The following is a description of a gene set: species: Mus musculus Mouse Gene Set: GOBP_POSITIVE_REGULATION_OF_PROTEIN_UBIQUITINATION Any process that activates or increases the frequency, rate or extent of the addition of ubiquitin groups to a protein., and this is the list of marker genes: Peli1, Arrdc4, Ube3a, Dnajb2, Rassf5, Ndfip2, Bcl10, Derl1, Fam107a, Hamp, Plk1, Ube2l3 (NCBI Gene Id 98018), Mycbp2, Spsb4 (splA/ryanodine receptor domain and SOCS box containing 4), Kdm1a, Cul3, Aimp2, Fbxo4, Skp2, Nmi, Mapk15, Fanci, D1Pas1, Paxip1, Pttg1ip, Fancm, Stub1, Btrc, Nsmce3, Amer1, Nod2, Axin1, Fbxw7, Marchf7, Rnf180, Cdk5rap3, Bmi1, Phf23, Mastl, Ube2v2, Ngf, Ptpn22 (protein tyrosine phosphatase, non-receptor type 22 (lymphoid)), Xiap, Rnf40, Prkn, Rbx1, Trib2, Angpt1, Fzr1, Birc3, Ube2n (NCBI Gene Id 93765), Arrb1, Ubqln1, Tm9sf5, Tspyl5, Laptm5, Rnf111, Mapk8 (NCBI Gene Id 26419), Sphk1 (sphingosine kinase 1), Mapk9, Klhl40, Dnaja3, Birc2, Cdc20, Birc5, Ripk2, Tbc1d7 (NCBI Gene Id 67046), Skp1, Arrdc3, Senp2, Rps2, Huwe1, Ndfip1, Cblb, Ube2srt, Septin4, Wbp1l (WW domain binding protein 1 like), Ube2d1, Fgfr3, Cd300ld3, Nhlrc1, Pef1, Gsk3a (glycogen synthase kinase 3 alpha), Wfs1, Pdcd6, Hspa5, Rbx1-ps, Pten, Psmd10, Rassf1, Ube2v1, Cav1, Npm1, Ube2s, Gabarap, Cdc14b, Trib3 (tribbles pseudokinase 3), Hamp2, Ubb, Rchy1, Birc7, Trib1, Cry1, Hspbp1, Ticam1, Hdac3, Inava, Chfr, Commd1, Mta1, Sprtn, Nscme3l, Prickle1, Lrrk2, Gsk3b, Topors (topoisomerase I binding, arginine/serine-rich), Fbxo33, Ddx3x